The following is a description of a gene set: IL-10 or IL-6 stimulation of control 129xC57BL/6 murine bone marrow derived macrophages in the presence of LPS. We used microarrays to detail the global programme of gene expression changes in response to IL-6 or IL-10 stimulation in the presence of lipopolysaccharide. BMDMs were isolated from control, IL-6-/-, and IL-10-/- mice on a 129XBL/6 mixed background mice and differentiated in the presence of CSF-1 for 6-7 days. Cells were scraped and plated in 6 well plates at 2x10e6/well. Cells were washed with complete DMEM and rested for 1-2 hr before stimulation with combinations of IL-10 (10 ng/ml), IL-6 (2 ng/ml) or LPS (100 ng/ml) for 45 min or 180 mins. Complete biological replicates were performed. from publication El Kasmi KC, Holst J, Coffre M, Mielke L, de Pauw A, Lhocine N, Smith AM, Rutschman R, Kaushal D, Shen Y, Suda T, Donnelly RP, Myers MG Jr, Alexander W, Vignali DA, Watowich SS, Ernst M, Hilton DJ, Murray PJ (PMID 17114459) Human Gene Set: GSE5589_UNSTIM_VS_45MIN_LPS_STIM_MACROPHAGE_DN species: Homo sapiens Genes down-regulated in bone marrow-derived macrophages: untreated (0 min) versus LPS (45 min)., and this is the list of marker genes: UQCRB, EDF1, PHLDB1 (NCBI Gene Id 23187), TMEM35B, OAZ2, LEAP2, REC114, CDH6, ARFGAP1, SLC35F6, ANKUB1, TMEM213, DMAC1, SCUBE1, NOD1, COX4I2, CTPS2, TLR2, KCNQ3, CUEDC2, MAN2A2, BHLHE40, HDAC5, CDK10, ERI3, DBH, UBXN6, DCAF8, HNRNPA2B1, CITED2, CPSF1, PRRC2A, KLHL24, NOP10, TSC2, MRPS21, ATP6V1F, TMEM92, GDPD5, ANAPC2, NCOR2, TEF, STRC, RNF5, RTN3, SCARB1, IER5, AQR, TMED4, CLDN7, EIF4EBP2, OR10AD1, UCHL1 (ubiquitin C-terminal hydrolase L1), UBAP2L, RDH10, ARHGAP33, OPA3, USP13, TRMT1 (tRNA methyltransferase 1), CDKAL1, XAB2, ZFYVE19, ALDOA, RRP1, SLC16A9, SLC34A1, DRGX, H2BC3, DPCD, NFIB, FOXRED1, TMEM131, CLEC4G, TBCE, STT3A, PAN3, MON1A, DCTN2, DTD2, WDR26, METAP1D, SLC27A4, RBIS, ABHD4, NPPC, RPL36, MFAP3, TALDO1, QKI, HAPSTR1, ACTL10, LELP1, XIRP1, NFXL1, POLR2K, NDUFA7, ACO1, THOC3, COMMD4, SIPA1, MBTPS1 (NCBI Gene Id 8720), AHCYL2, PCYT2, C19orf44, GPR158, ZNF526, SKP1, TNFRSF17, AKIP1, IRAK1, MAP4K2, HTRA3, UBAP1, RAP1B, DYNC1H1, BLTP2, STAB1, SSB, WBP1, BAX, HBA2, RANBP17, AP2S1, TACR1 (NCBI Gene Id 6869), TBL1X, NDUFA8, PRR13, EIF2D (eukaryotic translation initiation factor 2D), CORO7, GDE1, SHANK1, SCAMP5, MACO1, SLC22A12, COA8, TP53INP1, ING2, BTNL2, COQ7 (NCBI Gene Id 51672), GOSR2, ADORA3 (adenosine A3 receptor), SLC25A39, ARMCX6, CPSF3, CIAO2A, MVB12A, GMFG, SNX32, SSH1, ANKRD2, KRTAP2-4, HAT1, CD82, VPS51, CACNG5, BRS3, DCAF11, PDXDC1, MGAT4B, RPL11, VIRMA, IL17D, UPF2, RNF185, UQCRHL, BAALC, MFSD13A, EMC7, GLIS1, ZSWIM4, FETUB, CNBP, PTTG1, DCXR, ARHGAP23, HINT1, FRYL, GRHL2, EIF4G3, GADD45GIP1, NEDD8 (NEDD8 ubiquitin like modifier), NCAPH, ANAPC13, SLC35A2, MRPL28, LTC4S, HAGHL, COCH, SCN2B, HAGH, EPHB1, ATP4A, ZNHIT3, PDCD4, MEGF9, NUP214, DOCK5, TOR2A, GRINA, BHLHA15